Given this list of marker genes MEAF6, KLHL15, SPIDR, BRD8, RNF126, SHLD3, FIGNL1, RUVBL2, FUS, TEX15, MBTD1, FANCB, SHLD1, ING3, PPP4C, CSNK2A1, RTEL1, UBQLN4, MRNIP, PIAS4, PPP4R2, RAD51, POLQ, HELQ, MRGBP, KHDC3L, WRAP53, EP400, PARP1, WAS, YEATS4, USP51, FBH1, TIMELESS, TP53BP1, CHEK1, TERF2IP, OOEP, ACTL6A, MAD2L2, RPA2, ACTB, SIRT6, RUVBL1, KMT5A, TRRAP, SENP3, SHLD2, RADX, PARPBP, WDR48 (WD repeat domain 48), ZNF365, MORF4L1, SMCHD1, MAGEF1, SETD2, EPC1, RAD51AP1, PELI1 (pellino E3 ubiquitin protein ligase 1), C1QBP, RNF8, PRMT1, ERCC6, CGAS, VPS72, PLK1, CREBBP, MORF4L2, EPC2, ARID2, HELB, KAT5, DMAP1, RIF1 (replication timing regulatory factor 1), KDM1A, ACTR2, SKP2, ABL1, HDGFL2, RMI2, RECQL5, NBN, here is a description of the gene set: studied in species Homo sapiens Human Gene Set: GOBP_REGULATION_OF_DOUBLE_STRAND_BREAK_REPAIR_VIA_HOMOLOGOUS_RECOMBINATION Any process that modulates the frequency, rate or extent of the error-free repair of a double-strand break in DNA in which the broken DNA molecule is repaired using homologous sequences.